The following is a description of a gene set: studied in species Mus musculus Mouse Gene Set: GOBP_LOCOMOTION Self-propelled movement of a cell or organism from one location to another., and this is the list of marker genes: Dusp10, Fgf2, Rtn4rl1, Syne2, Pdcd10, Sema4g, Fam107a, Mtor, Rcan2, P2ry12 (NCBI Gene Id 73058), Sema3b, Rgcc, Scg2, Ptprg, Rpl13a, Mmp1a, Elp3, Podn, Wasl, Map3k3, Nisch, Ppia, Eng, Dpysl3, Cxcl1 (C-X-C motif chemokine ligand 1), Tacr2, Prex1, Bmpr1a, Fer, Cfap20, Lama2, Tbc1d24, Adipoq, Ccn1, Scrt2, Psen1, Il1rn, BC037156, Apela, Sod2, Nkx6-1 (NCBI Gene Id 18096), Hdac5, Vps35, Pik3cb, Dock7, Spag9, Miip, Tsc2, Mst1, Col1a1, Fpr3, Med23, Pak1, Amot, Gata2, Map3k7, Dusp3, Ackr4, Sema6a, F7, Ptprc, Hdac1, Adora3, Tacr3, Fgf22, Pik3r2, Cxcr5, Mmp14, Camk2b, Fgr, Rin3, Cxcl13, Cd63, Cdk5, Cass4, Ptafr, Cldn5, Svbp, Ccl11, Cx3cl1, Acvrl1, Rabgef1, Col6a1, Lyve1, Plekhg3, Rock1 (NCBI Gene Id 68785), Srp54a, Il6st, Tbr1, Pdgfrb, Lrig2, Diaph1, Zfp640, Sorl1, Fermt1, Cdh5, Ptk2b, Plxnc1, Msmp, Adra2a, Furin, Ntng1, Bst1 (bone marrow stromal cell antigen 1), Uts2, Cdh1, Ccl1, Lmna, Nox1, Lgals3, Sema3f, Apoa1, Spata13, Cx3cr1 (C-X3-C motif chemokine receptor 1), Akap12, Drd2, Clic4, Ecscr, Casp8, Padi2, Ccl21a, Clec7a, Cdkn1b, Ccl8, Slamf8, Grin2c, Cep43, Usp14, Fuz, Rhoc, Gla, Krit1, Agt, Acvr1c (NCBI Gene Id 269275), Ccl26 (NCBI Gene Id 541307), Rab11a, Fgf23, Bex4, Perp, Ppm1f, C3ar1, Lef1, Tbccd1 (TBCC domain containing 1), Emilin2, Erdr1, Cd200r1, Elp5, Bmp7, Zfp609, Foxo3, Tnfsf11, Gpld1, Itga2b, Tmsb15a, Pkp2, Cyp1b1 (cytochrome P450, family 1, subfamily b, polypeptide 1), Ackr3, Fam89b, Ccr2, F2rl1, S100a9, Cxcl11, Defb5 (defensin beta 5), Tymp, Rapgef3, Duox2, Xcl1, Hras, Il1b, Cln6, Daam2, Pin1, Ptger4, Lect2, Fpr-rs3, Ccr10, Rps19, Tjp1, Acp5, Ninj1, Creb3, Ccdc25 (NCBI Gene Id 67179), Prkd2, Prr5, Nodal, Mpp1, Ccar1, Cxcr3, Fga, Ephb2, Insl3, Gstp1, Rnase2b, St3gal4, Lrrc15, Mapk1, Gdf2, Acvr1b, Bcl6, Was, Peak1, Ccn3, Fadd, Fut7, Il24, Card10, Angpt2, Gtpbp4, Arhgap5, Bmper, Plau, Stk10, Fpr2, Myoc, Gria1, Ssh1, Duoxa2, Agr2, Egr3, Ptpru, Rac3, Unc5c, Anxa5, Gli1, Pfn1, Sema3e (NCBI Gene Id 330043), Ccl20 (NCBI Gene Id 20297), Epb41l4b, Rhod, Eppin, Ccrl2, Ajuba, Ntrk3, Mmp7, Jcad, Cldn19, Ttll6, Arhgap18, Egfl7, Sema4a, Adam9, Spp1, Fpr-rs7, Numb, Grin1 (glutamate receptor, ionotropic, NMDA1 (zeta 1)), Mif, Arhgef16, Ccl5, Adamts1, Srf, Itgb2l, Ednra, Afdn, Mstn, Cd47, Fgf6, Arhgap4, Arhgap32 (Rho GTPase activating protein 32), Cxcl17, Grb7, Ddrgk1, Tff2, Sparc, Mcc, Carmil2, Fzd4, Ppp3ca, Adipor2, Ccr1, Ldb2, Adam10, Saa3, Ntn1, Gab1, Osbpl8, Nexmif, Gp1ba, F2r, Ing2, Kif21a, Fut9, Kdr, Spn, Atp8a1, Il17b, Sp1, Mmp3, Smarca4, Tbxa2r, Pdgfra, Glipr2, Atoh8, Cited2, Slc37a4, Cd69, Coro1a, Nus1, Snai1, Ptprm, Jph3, Atp1a2, Ccl21f, Pik3cg, Ptpn2, Tafa5, Dmtn, Sema3d (sema domain, immunoglobulin domain (Ig), short basic domain, secreted, (semaphorin) 3D), Cmtm3 (CKLF-like MARVEL transmembrane domain containing 3), Agtr1a, Arpc2, Fam83h, Arsb, Atp5f1b, Defb48, Gpr15lg, Epb41l5, Plxnb1, Il27ra, Ccr4, Cxcr6, Bsg, Tmigd1, Rock2, Plet1, Mta2, Syk, Rhob, Ccl4, Rapgef4, Chga, Krt16, Tpm1, Stat3, Gas2l2, Elane, Nherf1 (NCBI Gene Id 26941), Sema5a, Cln3, Bin2, Hmgb1, Akt2, Mmrn2, Sap30, Alox5, Evl, Cxcl10, Ccdc39, Fbn2, Nrp1, Drd3, Ythdf3, Rnf41, Igf2, Col3a1, Anxa1, Crkl, Ptpn22, Kif26a, Capn7, Ago2, Apod, Itgb1bp1, Mitf, Synj2bp (synaptojanin 2 binding protein), Syde1, Nsmf, Ptpn23, Bmp4, Sec1, Srgap3, Artn, Fermt3, Fn1 (NCBI Gene Id 269206), Coro1b, Fbxo31, Robo3, Gna13, Lama5, Maz, Mmp2, Nefl, Ppib, Map3k1, Ezh2, Ldlrad4, Ccl21b, Pdcd6, Elp6, Bdkrb1, Nedd9, Xbp1, Abhd6, Prkcq, Ube2i, Rhog, Nck1, Icam1 (intercellular adhesion molecule 1), Vash1, Ptpro, Cxadr, Tac4, Sema3a, Mctp1, Cyp19a1, Rbbp7, Klrk1, Rin2, Stk26, Rps6kb1, Csf1r, Lrrk2 (NCBI Gene Id 79409, leucine-rich repeat kinase 2), Egf, Gpr37, Sele, Cnn2, Lama3, Dnm1l, Cadm4 (NCBI Gene Id 260299), Ptk2 (NCBI Gene Id 14083), Ythdf1, Trem3, Mir218-1, Pik3cd, Idh2, Bcar1, Emilin1, Tnfsf18, Ctsg, Sucnr1, Lamc2, Magi2, Hoxb9, Aire, Plcb1, Fgf5, Il34, Dnai3, Gpi1, Ccl28, Ccl21d, Emp2, Cxcr1, Gab2, Atp2b4, Has1, Ldb1, Dock4, Ttbk2, Cldn1, Tmsb10, Hdac4, Snca, Srpx2, Ghrl, Itgax, Cxcl2, Ceacam1, Stk24, Ptn, Ngfr, Mir218-2, Rreb1, Ap1ar, Mien1, Ctnna1, Maco1, Akt1, Onecut1, Jak2, Phlda2, Rack1, Irs1, Csnk2b, Ripor2, Patz1, Zc3h12a, Nrg3, Ecm1, Robo4, Sema4f, Edn2, Tbx5, P2ry6, Tgfb2, Crk, Macir, Ddr2, Klf4, Il23a, Fut4, Pdgfb, Dock8, Pik3c2g, Swap70, Pde4b, Fgf16, Ccr6, Cers2, Nox4, Pde4d (NCBI Gene Id 320753), Trem2, Cxcl14, Tmsb15b2, Itgav, Mmp12, Hmgb2, Nr4a3, Pak3, Ccl25, Gstp2, Abcc1, Gfus, Kitl, Ep300, Prkg1, Rnase2a, Stx4a, Spry2, Ccl22, Aldoa, Megf8, Agrn, Sema4b, Sirt1, Clasp2, Plxnd1, Map2k3, Atp7a, Mospd2, Drd4, Cxcr4, Serpinf1 (NCBI Gene Id 20317), Mef2c, Ghsr (growth hormone secretagogue receptor), Ednrb, Igfbp3, Pf4, Mapk8ip3, Adarb1, Dcn, Oxsr1, Sun2, Sap30l, Gpnmb, Sbds, Ogt, Cd9, Emc10, Defb8, Ffar2, Pdgfc, Glul, Ctsh, Pla2g7, Bmp10, Trpv4, Ptgr1, Wdr44, Spns2 (NCBI Gene Id 216892), Ppp3cb (protein phosphatase 3, catalytic subunit, beta isoform), Creb1, Mmp10, Pin1rt1, Rcan1 (NCBI Gene Id 80500), S1pr1 (sphingosine-1-phosphate receptor 1), Rac1, Igsf10, Mink1, Abcc8, Mapk15, Trf, Ntf3, Thbs4, Htr1d, Mylk, Bcas3, Apoe, Irgc, Tnc, Sh3bp1, Shtn1, Tacstd2, Mysm1, Wnt3, Mgat3, Ifnb1, Sema5b, Tubb2b, Cldn13, Angptl3, Bmp2, Thy1, Lamb1, Adam17, Ccl21e, Ctnna2, Gsx2, Tert (NCBI Gene Id 21752), Chrm1, Clxn, Itga6, Rhoj, Rab13, Foxp1, Colec10, Selenok, Ackr2, Tac1, P2ry2, Dicer1, Macf1, Fut1, Atm (ataxia telangiectasia mutated), Catsper1, Epha7, Apex1 (NCBI Gene Id 11792), Pkn2, Ccr7, Scn1b, Efnb2, Blvra, Rogdi, Onecut2, Gpr173, Gcnt2, Tgfbr3, Cmtm5, Chrd, Mcu, Bst2, Tirap, Ifitm1, Abi3, Duox1, Park7, Stx3, Adamts9, Lama1, Epha4, Pfn2, Ssh2, Dach1, Cysltr1 (cysteinyl leukotriene receptor 1), Myo9b, Ccl2, Smpd3, Nbl1, C5ar1, Dock10, Grn, Mdk, Tpbg, Shh, Tmeff2, Dsg3, Efemp1, Itga2, Rapgef2, Alkbh1, Fbxo5, Srgap2, Plp1, Cdh13, Cnr2, Mgat5, Tppp2, Fgf18, Camsap3, S100a8, Tnf, Ano6, Stk39, Tac2, Prag1, Adtrp, Sfrp2, Epha1, Gcsam, Drd1, Csf2, Tex101, Slit2, Jun, Parva, Pparg, Wnt5b, Adora1, Hrg, Defb33, Plk2, Ptprt (protein tyrosine phosphatase receptor type T), Cmtm8, Slc8a1, Robo1, Wnt3a, Itgb3, Ppargc1a, Nup85, Rap2a, Fas, Fignl2, Sema4d, Sin3b, Nav3, App, Plxnb2, Fgf17, Adgra2, Trim32, Il33, Trp53, Il17ra (NCBI Gene Id 16172), Spred1, Defb4, Slamf1, Mdm2, Reln, Alox12, Ret, Fgf7, Abr, Gadd45a, Plekhg5, Elmo2, Angpt4, Eppk1, Jam3, Tgfb1, Sema6c, Vegfa, Gpr18, Lmo4, Hspa5, Adam15, Plgrkt, Dab2, Cldn7 (NCBI Gene Id 53624), Cav1, Ttn, Edn3, Rgn, Trpm4, Cd200, Efna5, Dock2, Selp, Carmil1, Cxcl15, Enpp2, Smurf2, Jam2, Tnr, Meak7, Rcc2, Pikfyve, Arid2, Cxcl5, Tacr1, Dbn1, Ifng, Foxo4, Cpne3, Zfp580, Rap2b, Rab25, Cemip, Pld2 (NCBI Gene Id 18806), Tnfrsf18, Prcp, Ssx2ip, Flrt3, Arid4b, Ppard, Trem1, Efna1, Gnrh1, Dusp1, Jup, Diaph2, Zfp703, Ndrg4, Lcn2, Wdpcp, Pik3c2a, Bex6, Jaml, Ptprr, Cd151, Gsk3b, Cygb, Tie1 (NCBI Gene Id 21846), Phactr1, Gpr183, Cdh11, Igf1, Nipbl, Fpr-rs4, Zswim6, Dscam, Map2k5, Slk, Wnt5a, Myh9, Madcam1, Cbll1, Plcg2, Mapk3, Ccl19-ps3, Slc26a5, Vtn, Nf1, Vegfc, Slamf9, Spint2, Bcl2, Camk1d, Atp1a3, Ada, Slurp1, Hcrtr2, Mecp2, Stap1, Gm6040, Kif14, Myadm, Ccr8, Ascl2, Sh3rf2, Ccl27a, Arhgdia, Ripk3, Retn, Hyal2, Dapk2, Ephb1, Nr4a1, Lgals9, Cxcr2, Mkks, Fat1, Plcg1, C1qbp, Pgr, Bmpr2, Bcr, Prr5l, Ptpn1, Fbln1, Tek, Srcin1, Defb7, Fpr1, Acta2, Fbxo7, Calr, Vav1, Pecam1, Cd274, Il12a, Lyn, Zp3, Sdc3, Il18, Vav3, Slc25a46, Muc2, Apoh (apolipoprotein H), Nckap1l, F3, Sin3a, Mmp9, Psen2 (NCBI Gene Id 98295), Wnt7a, Actg1, Wnt4, Dpep1, Sema3c, Abl1, Hace1, Stc1, Itgb1, Lgr4, Tnfsf4, Stat5b, Gm5849, Tlr4, Rhoa, Rbbp4, Cpeb1, Nova2, Wnt7b, Itgb2, Adora2b, Ccl3, Nr2f2, Ripor1 (NCBI Gene Id 75687), Bag4, Arhgdib, Actn4, Hnf4a, Abl2, Hyal1, Iqsec1, Akirin1, Pip5k1a, Osgin1, Sfrp1, Src, Has2, S100a11-ps, Dlc1, Retnlg, Fubp1, Podxl, Fezf2, Ccl19-ps1, Timp1 (NCBI Gene Id 21857), Tnfaip6 (tumor necrosis factor alpha induced protein 6), Mycbp2, Stard13, Map2k2, Tfap2a, Opn4, Nog, Lrch1, Arhgef2, Prkce, Or10j5, Pkn1, Hmox1, Cd81, Arpin, Il17rc, Pdgfd, Mcam, Rnf7, Cul5, Cd99l2, Plec, S100a4, Clasp1 (CLIP associating protein 1), Ptprk, Nod2, Zeb2, Cib1, Atp2b2, Igfals, Scrib, Fcgr3, Defb37, Nrg1, Cxcl3, Plxnb3, Amotl2, Inpp5f, Rigi, Tradd, Ccl19-ps4, Pten, Hdac2, Rnf20, Rnase10, Fes, Ppbp, Hdac6, Smad3, Ccn4, Acvr1 (activin A receptor, type 1), S100a11, Gnai2, Cavin1 (caveolae associated 1), Ccl17, Rras, Gna12, Sap130, Robo2, Ccl19-ps5, Sox14, Lpar1, Vil1 (villin 1), Fgf21, S1pr2, Ccl19, Csf3r, Lsp1, Ptprz1, Pou4f2, Fgf3 (NCBI Gene Id 14174), Ptprj, Cxcl12, Trpm2, Ear14, Defb14, Defb1, Irs2, Plxna1, Erbb4, Meox2, Appl1, Ccl19-ps6 (C-C motif chemokine ligand 19, pseudogene 6), Defb6, Fgf1, Arhgef39, Iqcf1, Pip5kl1, Col18a1, Tnfrsf14, Nos3, Ccr9, Ear1, Aif1, Grin2a, Ilk, Rufy3, Pawr, Plg, Notch1, Ccl7, Tafa4, Tmem201, Nkx2-1, Adipor1, Mia3, Sema6d, S2bpcox16, Scrt1, Myo5a, Itga5, Rho, Agtr1b, Kif9, Cyp7b1, Prl2c2 (prolactin family 2, subfamily c, member 2), Tmsb15b1, Pld1, Hsd3b7, Arrb2, Ptger3, Ccr5, Ager, Pdgfa, Vim, Tgfbr1, Srgap1, Fgf10, Il1a, Dll4, Prkcd, Pycard, Atp1b2, Itga9, Rras2 (NCBI Gene Id 97407), Ing1, Cmtm2b, Abhd2, Bmerb1, Wfdc6b, Map4k4, Prkd1, Fbxw7, Dab2ip, Myc, Krt5, Tshr, Ccl12, Tcaf1, Ccr3, Cxcl16, Csf1 (NCBI Gene Id 97111), Sema4c, Epha3 (Eph receptor A3), Ear10, Bbs1, Adgrg1, Map2k1, Frmd5, Trp53inp1, Sst, Ntng2, Lgr6, Dpp4, Cfap69, Tnfsf14, Dnaja4, Fpr-rs6, Nrp2, Wnk1, Lrp2, Chst4, Zmynd8, Itga4, Kiss1r (KISS1 receptor), Prl7d1, Mapk8, Gbf1, Kif2a, Unc5d, Smim22, Edn1, P2rx4, Sema6b, Casr, Adam7, Ccbe1, Pik3r1, Gpsm3 (G-protein signalling modulator 3 (AGS3-like, C. elegans)), Gper1, Fgf8, Rffl, Rap2c, Flt4, Akt3, Prdm14, Bbs4, Myd88, Foxf1, Prok2, Il1r1, Mtus1, Xcr1, Aqp1, Adgrg3, Cmklr1, Postn (periostin, osteoblast specific factor), Ccl24, Msn, Ear2, Plvap, Aoc3, Suds3, Hc, Fgf9, Lbp, Twist1, Dock5 (dedicator of cytokinesis 5), Wdr62, Angpt1, Vsir, Cxcl9, Ip6k3, Cmtm2a, Rtn4, Myo1c, Brinp2, Gm266, Mmrn1, Amotl1 (NCBI Gene Id 75723), Cldn4, Cd300a, Pdpk1, Prox1, Kit, Egr1, Rarres2, Marveld3, Drd5, Kiss1, Slc8b1, Defb3, Sema7a, Wdr1, Tgfbr2, Vcl, Chst2, Tet1, Rtn4r, Spi1, Epcam, Vegfb, Cdc42, Cd74, Capn1, Jag1, Myocd, Adam8, Stmn1, Camk2a, Plpp3, Sinhcaf, Prkca, Dlg5, Ch25h, Tlr2, Hdac7, Sell, Rdx, Lox (NCBI Gene Id 16948), Pla2g6, Iqgap1, Vrk1, Nppc, Reck, Vegfd, Dusp22, Rnase9, Il16, Vcam1, Cldn3, Lama4, Nfe2l2, Cttn, P4hb, Thbs1, Adgrb1, Ear6, Hif1a, St6gal1, Sdc4, Tmigd3, Ptgdr2, Fgf15, Twist2, Grem1, Brms1, Spinkl, Wnt11, Cfap45, Gja1, Defb25, Or4m1, Arhgef5, Insr, Itga1, Pax6, Braf, Plaa, Coro1c, Atoh7, Tmem196, Appl2, Dapk3, Plxna4 (plexin A4), Pgf, Ppp2r3a, Gdf15, Cfl1, Myo1f, Adgrl3, Dock1, Ccl9, Tiam1, Cyrib, Cort, Cmtm7, Plxna3, Ets1, Ccl6, Limch1, Mapre2, Pcsk5, Prkx, Arid4a, Acan, Sphk1, Sema3g, Stat5a, Arrdc3, Hspb1, Ulk4, Hdac9, Gpr35, Ryk, Kank1, Dag1, Ccr1l1, Snai2, Kif20b, Pdpn, Phpt1, Igfbp5, Tnn, Egfr, Bbs2, Arf6, Fgf20, S100a7a, S100a14 (NCBI Gene Id 66166), Pitx2, Fgfr1, Anxa3, Slc12a2, Foxc2, Sp100, Bves, Ccdc125, Fgfbp1, Gcnt1, Stk4, Apc, Flrt2 (fibronectin leucine rich transmembrane protein 2), Defb47, Smo, Sox9, Tmsb4x, Atp5f1a, Itga3, Smoc2, Synpo2, Met, Ace (NCBI Gene Id 11421), Igf1r, Gata3, Phldb2, Insm1, Nr2e1, Gas6, Camk2d, Hgf, Sash1, Chrm4, Tmem102, Brms1l, Dysf, Usp17le, Epha2, Fam110c, Lyst, Shank3, Pip5k1c, Nexn, Hbegf, Flt1, Itgam (NCBI Gene Id 16409), Ptgs2, Hoxa7, Lgmn, Cd40, Cripto, Trip6, Il4, Scai, C5ar2, Fermt2, Rac2, Trib1, Fgf4, Igsf8, Mmp28, Lrp1, Cfap206, Serpine1, Slit1, Ror2, Cklf, Flna, Defb46, Fcer1g, Sulf1, Ptp4a1, Plxna2, Slit3, Sdcbp, Wfdc6a, Actr3